The following is a description of a gene set: from publication Chen Y, Wang X (PMID 31504780) Human Gene Set: MIR598_5P studied in species Homo sapiens Genes predicted to be targets of miRBase v22 microRNA hsa-miR-598-5p in miRDB v6.0 with MirTarget v4 prediction scores > 80 (high confidence targets)., and this is the list of marker genes: GRIA1, EBF1, PLCXD1, KRT80, LMAN2L